The following is a description of a gene set: Any apoptotic process that occurs in a hippocampal neuron. Human Gene Set: GOBP_HIPPOCAMPAL_NEURON_APOPTOTIC_PROCESS studied in species Homo sapiens, and this is the list of marker genes: TREM2, ELK1, CX3CL1, LCN2, PARP2, STAMBP, DRAXIN, CX3CR1